The following is a description of a gene set: Human Gene Set: GSE10325_LUPUS_BCELL_VS_LUPUS_MYELOID_UP species: Homo sapiens Gene expression profile studies have identified an interferon signature in whole blood or mononuclear cell samples from patients with systemic lupus erythematosus. This study was designed to determine whether specific lymphocyte and myeloid subsets freshly isolated from the blood of systemic lupus erythematosus patients demonstrated unique gene expression profiles compared to subsets isolated from healthy controls. Genes up-regulated in comparison of systemic lupus erythematosus B cells versus systemic lupus erythromatosus myeloid cells. from publication Hutcheson J, Scatizzi JC, Siddiqui AM, Haines GK 3rd, Wu T, Li QZ, Davis LS, Mohan C, Perlman H (PMID 18275831), and this is the list of marker genes: NIT2, ODC1, GTF3A, IGHA1, GOLGA8B, IGKV1D-13, PAOX, ASNS, TSPAN13, SIDT1, ZNF107, IL2RG, HINT1, TMEM14A, RHOH, PIK3C2B, TCF3, GOLGA8A, RPS5, RPL35, MDN1, NKRF, MDC1, SLC25A38, PTMA, SPIB, SPTBN1, HTRA2, DNAAF5, TRMT112, AGPAT5, SUZ12, ITPR3 (NCBI Gene Id 3710), ARPC5L, PHLPP2, PEBP1, IGKC, BCAS4, JCHAIN, AKR1B1, BANK1, PDLIM1 (PDZ and LIM domain 1), RFC4, TCEA1, STK17A, RCN2, E2F5, DPH2, PRKD2, QRSL1, EHD3, MAGED1, P2RX5, IGKV4-1, ZNF253, GPX7, CCNB1IP1, TUT4, PNOC, NUP88, PFAS, TPD52, PFKM, PIM2, SNRPD2, GNG7 (G protein subunit gamma 7), ADK, RASGRP1 (RAS guanyl releasing protein 1), SP140, ZHX2, ITM2A, BMS1P20, ACYP1, FAM30A, ZBTB25, SOD1, ITM2C, PPP3CC, DIPK1A, LIG1, BCL11A, PTPRCAP, CAD, NOLC1, CTC1, PCDH9, ST6GAL1, RPUSD2, PARP1, TMEM243, OXCT1, LRBA, RBBP7, DLEU1 (NCBI Gene Id 647154), TCL1A, ISCU, CHD7, CDC25B, PJA1, CDK5RAP2, STAP1, MS4A1, NCOA3, IGHM, DCTPP1, ADAM19, IGLV1-44, RANGRF, FCRL2, CD69, NUCKS1, SFMBT1, RRAS2, POU2AF1, CUTA, HLA-F-AS1, LDHB, IRF4, CD19, HMCES, RASGRP3, SS18L2, ABLIM1, UXT, HMGN1, ARID5B, RPSA, RPS10P5, GUSBP11, FCMR (Fc mu receptor), PWP1, ZNF85, FOXO1, FAM3C, PTPN4, SETBP1, SINHCAF, POLR3E, MCM3, TLE1, BLNK, ARPP19, IGHD, REXO2, PAX5 (paired box 5, NCBI Gene Id 5079), LAS1L, EEIG1, NOL11, SMYD3, GSPT2, RBM15, PKIA, FCHSD2, CD72, IARS1, TRAF5, ATF7IP2 (activating transcription factor 7 interacting protein 2), BACH2, VPREB3, CD79B, LY9, SEL1L3, NGLY1, ATIC, SKAP1, MCM7, IGLL3P, PPP1R16B, ANKRD28, ATP2A3, TP53BP1, S1PR1, DPH5, SMC6, ALDH18A1, TOP6BL, CD79A, TCF4, NPM1, NOC3L, DNAJC9, KIF20B, SYNE2, SEPTIN6, LSM2, FBL, CLEC2D, PRPS1 (NCBI Gene Id 8254), TSPAN3, TRIB2, UBE2D2, RPL10A, LBH, EEF1B2, TTC27